The following is a description of a gene set: Bilateral cleft lip Human Gene Set: HP_BILATERAL_CLEFT_LIP A non-midline cleft of the upper lip on the left and right sides. studied in species Homo sapiens, and this is the list of marker genes: GLI2, RAB5IF, SMPD4, SPOP, DLX4, PTCH1, FZD2, CHUK, SIX3, RSPO2, TP63, B3GLCT, MSX1, MED12, NECTIN1, IRF6, CILK1